The following is a description of a gene set: species: Mus musculus Human Gene Set: MIZUSHIMA_AUTOPHAGOSOME_FORMATION from publication Mizushima N, Yoshimori T, Levine B (PMID 20144757) Autophagy has been implicated in many physiological and pathological processes. Accordingly, there is a growing scientific need to accurately identify, quantify, and manipulate the process of autophagy. However, as autophagy involves dynamic and complicated processes, it is often analyzed incorrectly. In this Primer, we discuss methods to monitor autophagy and to modulate autophagic activity, with a primary focus on mammalian macroautophagy. Key proteins in mammalian autophagosome formation., and this is the list of marker genes: ATG3, ATG13, GABARAPL2, DCTN1, ATG14 (autophagy related 14), PIK3C3, ATG101, ATG7, AMBRA1, ATG10, ATG12, ATG5